The following is a description of a gene set: Comprehensive identification of all functional elements encoded in the human genome is a fundamental need in biomedical research. Here, we present a comparative analysis of the human, mouse, rat and dog genomes to create a systematic catalogue of common regulatory motifs in promoters and 3' untranslated regions (3' UTRs). The promoter analysis yields 174 candidate motifs, including most previously known transcription-factor binding sites and 105 new motifs. The 3'-UTR analysis yields 106 motifs likely to be involved in post-transcriptional regulation. Nearly one-half are associated with microRNAs (miRNAs), leading to the discovery of many new miRNA genes and their likely target genes. Our results suggest that previous estimates of the number of human miRNA genes were low, and that miRNAs regulate at least 20% of human genes. The overall results provide a systematic view of gene regulation in the human, which will be refined as additional mammalian genomes become available. Genes having at least one occurrence of the highly conserved motif M101 CTGCAGY in the regions spanning 4 kb centered on their transcription starting sites. The motif does not match any known transcription factor binding site. Human Gene Set: CTGCAGY_UNKNOWN studied in species Homo sapiens from publication Xie X, Lu J, Kulbokas EJ, Golub TR, Mootha V, Lindblad-Toh K, Lander ES, Kellis M (PMID 15735639), and this is the list of marker genes: KCNIP1, RGS2, PTCH1, CRIM1 (NCBI Gene Id 51232), HNRNPUL1, AK8, RND2, ZBTB25, GLI1, EVX1, ZDHHC5, MYO1F, CSRNP3, FSTL5, NSD3, SPRTN, TMEM131L, GTPBP1, PON1, NEDD4, ZMAT3, ZMYND8, WNT6, PWP2, RUSC1-AS1, SLC9A6, ADORA2A, KCND1, CAVIN2, SLITRK1, CCNE2, ANKRD28, LINC00477, TRPS1, SLC26A6, S100A1, MED12, PHF12, SASH3, FOXO3, MYO18A, LBX1, SYTL2, ADD3, INHA, ALCAM, PTX3, FNDC8, TSC22D1 (TSC22 domain family member 1), EPHA7, DSTN, MICU3, RYR2, PLPP5, NRG1, KCNIP4, CELF1, ID4 (NCBI Gene Id 3400, inhibitor of DNA binding 4), CNTN6, NKAPD1, ST8SIA4, DVL3, KDM3B, CPA4, DDX17, PID1, CDK9, TSPAN7, GPHN, GPR21, AP2A1, PPP2R5B, DCTN4, ETV1, MAP1B, NEXN-AS1, ARRDC3, ABCG1, MAF, NTRK2, MAP2K7, SERPINE1, PLA2G4B, PLXNB1, NEUROG1, ACVR1, CNMD, WWP1, BEND6, NKD1 (NCBI Gene Id 85407), BBX, NDUFB3, SH2D3C, CITED2, NCDN, RAB5B, BHLHE40, TUBA1A, ZNF711, TGIF1, PRDM13, MAGED1, BTF3P11, SLITRK5, SEC11C, NFIX, NRXN3, SYT3, DOK7, FBXW7, LHX4, DIS3L, GSK3B, EWSR1, DNAJB4, SORD, GRPR, MST1, SPOCK2, PICALM, FLRT3, ADNP, ETV4, SH3BGRL, QRICH1, SLCO5A1, USH1G, NXPH4, DMTF1, RHOBTB2, HAPLN4, GRIN2D, PNMA3, TUBA4A (NCBI Gene Id 93373), KMT2D, GAL3ST3, RCOR1, MAP4, ANGPTL8, STMN2, SEMA6A, ARMCX4, SPRED1, RHOA, TIMP4, SMARCD3 (SWI/SNF related, matrix associated, actin dependent regulator of chromatin, subfamily d, member 3), SGIP1, ENHO, CCNYL1, DBNDD2, DYNC1LI2, CDK6, PCDHB12, HPSE2, TMEM255A (NCBI Gene Id 55026), NLGN2, SHF, DEF6, USP20 (ubiquitin specific peptidase 20), AKT2, GTF2A1, RTKN, KCNS3, MTUS1, HOXA2, NRAS, BARHL1, RELL2, SEMA5B, NTN3, CACNB2, GNG3, SHFL, GAB2 (GRB2 associated binding protein 2), CTNND1, PRM2, SPTSSB, STAG1, LUC7L, JUNB, XPO1, CADM2, MEX3B, ARFGEF3 (NCBI Gene Id 57221), USP13, PTK2, NUP54, SARS1, USP21, TMEM132A, DLG2, SEPTIN4 (NCBI Gene Id 5414, septin 4), HOXB6, GRIA3, SLC4A10, FLT3, HOXB8, IER5L, ZMYM2, HIRA, COL7A1, NDUFB8, GABRQ, NXF1, LRRC8A, DCX, TFDP2, TGIF2, HRH3, TMEM256, FYTTD1, UAP1L1, CDK2AP2, NR3C2, CAP1, RIMS1, NBL1, ANGPTL2, MIR503HG, SLITRK3, MLX, RNF123, LGALS1, TFAP4, AMZ2P1, YWHAE, ARK2N, IL34, CCDC78, TTBK2, KLHL28, BEX3, VSNL1 (visinin like 1), NOL4, ZNRF1, SNURF, RTN4, GIT2, TBPL1, MIER1, RUVBL2, WNT2B, BAG4, COL11A2, CFL2, STOX1, CIDEB, PCDH17, MLLT10, RPS6KA3, COTL1, USP15, ZBTB45, RABAC1, NDUFA4, SHOX2, PHF6, RERG, PIP4K2A (phosphatidylinositol-5-phosphate 4-kinase type 2 alpha), DNM1, PTCHD4, EXOC8, NIBAN1, CALCR, DACT2, DMTN, CDH2, ABCD2, BCOR, PABIR2, PNRC1 (NCBI Gene Id 10957), ZSWIM8, TNFRSF12A, NBEA, GALK1, SALL1, TMEM191A, CAMK2D, HMGN2, MCF2, FGF12, TLCD3B, PCDHB4, RBFOX2, NIPBL, TNFRSF9, RPL28, ETV5, CD151, PDGFRB, GMPR, GARS1, FOS, TIGD2, PDGFB, PFN2, SGCG, SPRY4, ETFDH, MMP9, PRDX2, SOX10, CRIP2, PTPN14, GPM6A, ATG16L1, SOX4, TSC22D2, SH3BP1, STX16, RGL1, TBCC, PLA2G4D, CEP164, PHACTR3, UBE2E2, RBM45, KRTAP10-3, DEXI, HEY1, ADAMTS2, THEM6, PCDHB2, STIP1, TPPP3, ATP2C1, DPP9, FAM193A, CALN1, FBXO40, HGF, CBX8 (NCBI Gene Id 63441), SARM1, UHMK1, CBLN1 (cerebellin 1 precursor), PIK3IP1, RHOBTB3, SOX2, GGT7, RWDD4, EPB41L3, MINK1, TCTA, BRINP3, ANKRD55, JMJD1C, NEFL, ABCC6, TRIB1, TRAPPC11, PCDH9, STAT5B, SCN2A, LINC01931, RAB30, PCDH7, PCDHB11, KCNJ2, HDAC9, CCT6B, FHL1, NFKBIA, FRS3, RUSC1, CLUH, MAPK7, ADAM11, TAOK1, GANAB, FHL3, JAKMIP1, LRFN5, PTP4A1 (protein tyrosine phosphatase 4A1), TUBA1B, CHD6, SATB1, CNTD1, CCDC177, FST, PTGDS, RAP1GAP, TRIM3, IRS1, PUM2, APP, LRRC15, SLC2A12, CA7, SPACA9, OSBPL7, PCSK1N, RRAGB, C7orf33, GYS1, LY6H, HOXA3, DPYSL2, GRIN3A, SLC44A1, ATP1A3, MYLK2, ATP2B4, PRIMA1, JADE1, SLC22A17, UBE2L3, AR, SGCD, FGF11, MAP2K6, RARA, ADGRB2, KITLG, FNDC5, SLC12A5, AGAP1, DLGAP1, ZFY, MAP3K4, DIABLO, GJD4, EGR3, LSM1, NPAS4 (NCBI Gene Id 266743), LINC02908, STARD13, PRKAG1, KLF12, DSCAM, SHISA7, ANK3, FCRLB, CD27, SLC48A1, POU4F2, SPAG9, ATF7IP, AGO1, EIF4G2, TMEM74B, BSCL2, HCFC1R1, OTOP2, NDST2, COQ8A, OTOS, KCNE4, RAB3A (NCBI Gene Id 96387), NUAK1, VPS4A, EPB41, NRGN, KCNH2, CTTNBP2NL, BCL11A, SCAI, WBP2NL, ISOC1, CACNG3, BEX1, CIB3, GABRA3, DOC2A, MGAT4C, LCK, ARF3, COLCA1, PRICKLE4, INKA1, PPP1R21, ZNF532, DPYSL3, CACNB3, TMEM108, BSPRY, FLI1, CTNND2, DGCR8, HNF1B, TSHZ3, BRSK1, MAPT, SANBR, TTC19 (NCBI Gene Id 54902), SLC5A11, SOBP, POC1A, PAFAH1B1, CD99L2, HELZ2, LMO4, TMUB2, KLHL13, CNTN2, PCDHB15, FGF13, PPARGC1B, B3GALT2, RHBDD3, MAP1A, AMZ2, KLF10, PIK3R1, GRIK2, DEPTOR, RHOB, RELCH, TMEM132E-DT, ZFP36L1, IKZF2, PLCB3, FZD4, FNDC7, RNF145, C1QTNF3, HNRNPDL (heterogeneous nuclear ribonucleoprotein D like), ESRRG, TTC9B, SERPINF1, HERC1, LIMK2, CDKL5, VXN, LRP5, KMT2E, GPC3, RBM14, KIF3C, ATP6V1B2, SLC26A9, GRIN2A (NCBI Gene Id 2903), MAN1C1, TACC2, CCNDBP1, RAPH1, PDE4D, CHGA, DLC1, MRPL40, GNAI1, OMG, GDPD3, COA3, ZNF367, FGF14, PCDHB5, AXIN2, TMEM60, DUSP16, LYPD1, PRR7, DAB1, PIP5K1B, ERLIN2 (ER lipid raft associated 2), SNPH, LRP1B, IP6K2, GEM, SZT2, POLR3E, IFFO1, C11orf42, SORL1, TUBA4B, USP8 (ubiquitin specific peptidase 8), PPM1J, C11orf87, LRRTM1, HYCC2, CDH6, TCF15, ELF4, SMTNL2, BCL9L, MYPN, UPK2, KCNN3 (NCBI Gene Id 95947), MLF2, PPP2R2B, DPT, DCLK1, UNC50, CDH24, SLCO2A1, RABL6, CBFA2T3, HDAC3, DNMT3A, ELK3, EPB41L4B, GPR61, CIZ1, APLN, CD72, NRXN1, SCN8A, CCDC85B, PIN4, TSC22D3, ENO2, CALM1, SKIDA1, CARMIL3, PPP2R5C, PITHD1, DDX6, TNXB, PIM1 (Pim-1 proto-oncogene, serine/threonine kinase), FARP1, LRFN3, MIP, ARMC7, POGZ, ATP1B1, FBXW12 (F-box and WD repeat domain containing 12), AAMP, IGSF1, CACNG2, PRMT3, NNAT, JADE2, NSD1, CKMT1B, GRIA4 (glutamate ionotropic receptor AMPA type subunit 4), HRAS, CDK5R2, SYT12, FGFR1, LMX1A, FBXO9, L1CAM, RNF152, HOXA1, PELI3, PGF, OLFML2A, CSNK2A1 (casein kinase 2 alpha 1), SLC26A10P, TOGARAM1, MCAM (melanoma cell adhesion molecule), PRKD2, FGF1, MAX, RCOR2, RGS8, NAP1L2, CLSTN3, RAB3C, EAF1, PNMA6A (NCBI Gene Id 84968), CITED1, FGFR4, DUSP9, PDHA2 (pyruvate dehydrogenase E1 subunit alpha 2), HOXD4, RPUSD4, HFM1, EDA, COX18, C14orf119, CHST8, RBMS3, ANXA6, ESRRA, OPCML, SIPA1, LAMTOR1, PIH1D2, PLEKHA6, LMO3, APC2, LRRC3B, ARPC5, LINC01567, MAS1, CALM3, PTCHD1, CILK1, DLG3, FGF8, ANGPT2, MYO3B, PNKD, ZFX, SIRPA (NCBI Gene Id 96784), ITGA7, ZBTB47, MBNL2, NUDT14, METTL6, RAPGEFL1, CAMK1D, MAGED2, EGR1, STK4, EEF1DP3, TMEM132E, KIF17, RELT, WNK4, ATF4, PSD, DMD, THY1, C9orf78, HEXIM2, EPN3, MECOM, CNNM1, CAMK2G, TMTC2, KCNN2, NR2F1, GATA6, LMOD3, CASK, FAM81A, LPCAT4 (NCBI Gene Id 91188), NOVA1, IRF2BPL, EIF4A2, FRMD4A, TSPAN13, TMT1B, NLGN3, ACIN1 (apoptotic chromatin condensation inducer 1), FYN, ELAVL4, SNRPN, HOXA13, DUSP8, DNAI4, CDH13, ZNF777, PRRC2C, ANPEP, CASP10, ELMO3, HOXA9, UBR5, PAX6, DDX42, JARID2, BTBD9, KCNAB1, MYADML, MEIS1, NR1D1 (NCBI Gene Id 9572), GARNL3, FOXP1, KLHL40, ZBTB20, RAD51D, PAF1, DIO2, FOXN3, BDNF, CCDC47, STRIP1, LINC01341, DUSP3, ADGRB3, ELMO1, HACD3, GNA13, COPZ2, ACTR1B, FAM78A, FERMT3, PURA, CFL1, RBP5, GGNBP2, MOAP1, FGF9, ENKD1, ERG, IL1RAPL1, APBB2